Given this list of marker genes TUBB4B, TUBB8, TUBA3E, CLASP1, TUBB3, CLASP2, TUBB2A, TUBB, TUBB2B, TUBB4A, TUBA3D, TUBA8, MAPRE1, TUBA3C, CLIP2, TUBA1B, CLIP1, TUBA1A, TUBA4A, TUBA1C, TUBB6, TUBB1, here is a description of the gene set: Pathway Definition from KEGG: (CLIP1,CLIP2)+(CLASP1,CLASP2) == EB1 == microtubule Human Gene Set: KEGG_MEDICUS_REFERENCE_PROMOTION_OF_MICROTUBULE_GROWTH Promotion of microtubule growth. Pathway ID: N01553. Pathway type: Reference. Pathway class: nt06515 Regulation of kinetochore-microtubule interactions. studied in species Homo sapiens